The following is a description of a gene set: studied in species Homo sapiens Human Gene Set: REACTOME_REGULATION_OF_CHOLESTEROL_BIOSYNTHESIS_BY_SREBP_SREBF Regulation of cholesterol biosynthesis by SREBP (SREBF), and this is the list of marker genes: HMGCR, CYP51A1, FDPS, LSS, SP1, NFYB, HELZ2, INSIG2, CARM1, TBL1XR1, INSIG1, SREBF2, MVD, RXRA, TGS1, MVK, MBTPS1, PMVK, SMARCD3, NFYA, KPNB1, SEC24D, IDI1, MBTPS2, PPARA, DHCR7, CREBBP, NCOA6, GPAM, SCD, SEC24B, ACACB, SEC24C, NCOA2, CHD9, ELOVL6, SREBF1, ACACA, TBL1X, MED1, SEC23A, SAR1B, GGPS1, FDFT1, SEC24A, NFYC, SCAP, SC5D, RAN, SQLE, HMGCS1, MTF1, NCOA1, TM7SF2, FASN